Given this list of marker genes RHOD, EPHA2, DDR1, ITGA4, ITGB8, TNFRSF1A, WNT8B, ARHGAP1, FGD1, ITGB3, MMP11, DVL3, SMO, ITGA5, CTNNB1, CTNNA1, MMP2, EFNA5, ILK, SEMA3F, NME4, here is a description of the gene set: from publication Verrecchia F, Chu ML, Mauviel A (PMID 11279127) Human Gene Set: VERRECCHIA_RESPONSE_TO_TGFB1_C5 Cluster 5: ECM related genes up-regulated in dermal fibroblasts later than 30 min after TGFB1 addition; decreased slowly after the peak at 120 min time point. Despite major advances in the understanding of the intimate mechanisms of transforming growth factor-beta (TGF-beta) signaling through the Smad pathway, little progress has been made in the identification of direct target genes. In this report, using cDNA microarrays, we have focussed our attention on the characterization of extracellular matrix-related genes rapidly induced by TGF-beta in human dermal fibroblasts and attempted to identify the ones whose up-regulation by TGF-beta is Smad-mediated. For a gene to qualify as a direct Smad target, we postulated that it had to meet the following criteria: (1) rapid (30 min) and significant (at least 2-fold) elevation of steady-state mRNA levels upon TGF-beta stimulation, (2) activation of the promoter by both exogenous TGF-beta and co-transfected Smad3 expression vector, (3) up-regulation of promoter activity by TGF-beta blocked by both dominant-negative Smad3 and inhibitory Smad7 expression vectors, and (4) promoter transactivation by TGF-beta not possible in Smad3(-/-) mouse embryo fibroblasts. Using this stringent approach, we have identified COL1A2, COL3A1, COL6A1, COL6A3, and tissue inhibitor of metalloproteases-1 as definite TGF-beta/Smad3 targets. Extrapolation of this approach to other extracellular matrix-related gene promoters also identified COL1A1 and COL5A2, but not COL6A2, as novel Smad targets. Together, these results represent a significant step toward the identification of novel, early-induced Smad-dependent TGF-beta target genes in fibroblasts. species: Homo sapiens